The following is a description of a gene set: Human Gene Set: GSE15735_CTRL_VS_HDAC_INHIBITOR_TREATED_CD4_TCELL_2H_UP Histone acetyltransferases (HATs) and deacetylases (HDACs) function antagonistically to control histone acetylation. As acetylation is a histone mark for active transcription, HATs have been associated with active and HDACs with inactive genes. We describe here genome-wide mapping of HATs and HDACs binding on chromatin and ﬁnd that both are found at active genes with acetylated histones. Our data provide evidence that HATs and HDACs are both targeted to transcribed regions of active genes by phosphorylated RNA Pol II. Furthermore, the majority of HDACs in the human genome function to reset chromatin by removing acetylation at active genes. Inactive genes that are primed by MLL-mediated histone H3K4 methylation are subject to a dynamic cycle of acetylation and deacetylation by transient HAT/HDAC binding, preventing Pol II from binding to these genes but poising them for future activation. Silent genes without any H3K4 methylation signal show no evidence of being bound by HDACs. Genes up-regulated in CD4 T cells: control versus treated with HDAC inhibitors for 2h. from publication Wang Z, Zang C, Cui K, Schones DE, Barski A, Peng W, Zhao K (PMID 19698979) studied in species Homo sapiens, and this is the list of marker genes: PLPP3, SLC25A19, SZRD1, ACTR3B, LGMN, QSER1, FAM43A, MYO18A, ALCAM, PPM1E (NCBI Gene Id 22843), PMF1, TSPAN17, DCLK2, MPRIP, HEXD, NUAK2, GNG10 (NCBI Gene Id 2790), DUSP4, RPS6KA5, POU2F2, ADAM9, TRIM35, MARVELD2, RFC2, SLC2A6, DENND4A (DENN domain containing 4A), LIPE, RECQL5, PIK3CG (phosphatidylinositol-4,5-bisphosphate 3-kinase catalytic subunit gamma), DENND5B, ACSF3, BCL6, IRGC, RNF157, CFP, MID1IP1, SLC4A7, SNAP29, FGD2, TUBB2B, HDAC9, ATP13A2, MICU1, CD99, COPG2, FTX, NCF1, PLEK, ALG2, CAMK2D, PRUNE1, TFEB, PPP1R16B, LTA, SBK1, PLP2, GCOM1, AKT3, TACSTD2, CAPG, RASGEF1B, DPP7, EHD4, REL, SH2B3, NXPE3, MYO1E, ARHGAP24, POLR2A, RFX5, SLC48A1, MARCKS, CD40, BFSP2, TCF3, ADSS1, C9orf85 (NCBI Gene Id 138241), STOML1, ARL8A, CSK (NCBI Gene Id 1445), KLHL14 (NCBI Gene Id 57565), VARS1, OGFOD3, ABHD12 (abhydrolase domain containing 12, lysophospholipase), PLEKHM1, RUFY1 (NCBI Gene Id 80230), GCNT1, HPSE, TEP1, TRIOBP, CKAP4, CAPN5, SEMA4B, MGAT1, IRGQ, ECPAS, RAPGEF1, GNAQ, TMEM131L, FILIP1L, ZBTB22, APOE, SH3BGRL, ARHGAP21, OAT, TMED8, KTN1, ICOSLG, ST6GAL1, TMEM123, PRKCE, NMRAL1, ARHGAP17, IL18, PIKFYVE, IL5RA, EGR3, PRCP, KDM2A, E2F3, DENND3, PARVG, CLIC4, RIPK2, H2BC5, STAP1, EXOC6, COBLL1, MAPK11, VPREB3, LYNX1, RDH12, MAP4K1, BMP2K, FGR, TDRD7, NOXRED1, HEPACAM2, TASL, RGS18, QKI, CNR2, ABCB10 (NCBI Gene Id 23456), TXNDC16, RNF141, HMGN3, SFMBT1 (Scm like with four mbt domains 1), PTPN6 (protein tyrosine phosphatase non-receptor type 6), NDST1, DENND5A, RNH1, GPAT3, N4BP3, BIRC3, RABEP2, UNC119 (NCBI Gene Id 9094), FOXRED2, PLAC8 (placenta associated 8), EIF4EBP1, MTMR4, RFESD, USP6NL, KCTD14, POLD4, TYROBP, NUCB2, EDARADD, RAB31, CTSC, PRKCB, APOBEC3B, TLR4, PRKCD, CHD9, ANXA1, MGST1, IFT22, B3GNT8, CERK, CNPY3, IGKC, GRN, BCAR3, FMNL3, IFT172, IRAK3, ELL2, EFCAB2, SWAP70, CNRIP1, PSAP, HVCN1, INPPL1, SLC66A2, PFKFB4, ATP2A3, ZDHHC24, SERINC3, SH3BP2